Given this list of marker genes ATP6V1H, PPP4C, MYO5A, PPIC, NUP133, TMEM59, FRAT1, NBN, ITGAE, EFCAB11, AMDHD2, PFKL, KCNAB2, APPBP2, TMEM41B, XPO7, MAGED1 (NCBI Gene Id 9500), NPRL2 (NCBI Gene Id 10641), KRT1, IRF2, HSBP1, OARD1, TM6SF1, DYSF, PDCD4, NPTN, CASP8AP2, NXT2, BTN3A1, RUBCN (NCBI Gene Id 9711), TM2D1, MEAK7, TRPM2, ALOX5AP, SNRNP25, CTSH, LPCAT4, GIMAP6, LAPTM5, PTPN12, CDC7, TASOR, NDRG3, COL18A1, SLC9A1, PCYT2, CC2D1A, VIPAS39, ACTR1A, LAGE3, ATP5PD, INPP5B, RIPOR1, MICU1, PATZ1, ACADS, ENO3, GNB1, PEX14, OSTM1, NFKBIL1, CLIP1, YAF2, VOPP1, TDP2, UBE4A, MDC1, MKRN1, SH3BGRL3, NEK9, KIAA0319, PIGG, ITPR2, CHMP6, THEMIS2, STRADA, NTHL1, ST3GAL5, DHCR24, CAND1, ZNF682, E2F3, ERCC3, ECHDC2, CLUAP1, SOS1, MINPP1 (multiple inositol-polyphosphate phosphatase 1), PHYH, CDK19, KYAT1, HSD17B7, MED16, NFU1, MAP3K5, CSNK1G2, SLF2, PIGF, RMI1, AKAP7, CPT1A, ZYX, ATM, ANKZF1, PDE4DIP, XPNPEP1, PURA, ORC4, PHF20, SMC1A, SUMO2, MRFAP1L1, ITPK1 (inositol-tetrakisphosphate 1-kinase), MSRB2, EEIG1, SPOCK2, OSTF1, NAA40, WWP2, INPP5A, PARP4, WWC3, PCF11, LOXL2, C1orf159, CYB5R3, ADCK2, GNAI2, HTT, ABHD17A, SLC37A1, ZNF43, UBA3, HERC2, ILRUN, MRPL34, GTF2E1, DOK1 (NCBI Gene Id 1796), ACTL6A, BCL7C, LY96, YIPF1, PAQR4, ZNF266, CDIPT, LRRC20, IARS2, RCBTB2, NDUFA8, TRAF3IP1, CCDC69, ALDH3A2, NDUFS8, PPT1, CEP76, TMEM94, AMBP, MAPKAPK3, SLC33A1, FAM32A (family with sequence similarity 32 member A), FAIM, VAV1, INPP5E, AP3S1, MBP, NOTCH2, SHFL, ATAD2, MTMR1, SLC25A10, STAP1, KIF26B, OGFRL1, CZIB, USP39, KCTD2 (NCBI Gene Id 23510), PLK4, RAP1GDS1, PMVK, YLPM1, FANCG, F2RL1, LEPROTL1 (leptin receptor overlapping transcript like 1), ATP6V1A, DDC, RPL13P5, LAMTOR2, OMD, TPGS2, MAT2B, E2F1, AGL, EP300 (E1A binding protein p300), STX7, SV2A, HDAC6 (NCBI Gene Id 100820762), SQOR, THOC7, USP21, here is a description of the gene set: Expression profiling of Rag2-deficient Ets1++ and Rag2-deficient Ets1-- mature NK cells and WT bone marrow progenitors, WT T cells, and WT Pro B cells Human Gene Set: GSE37301_LYMPHOID_PRIMED_MPP_VS_CD4_TCELL_DN studied in species Homo sapiens from publication Ramirez K, Chandler KJ, Spaulding C, Zandi S, Sigvardsson M, Graves BJ, Kee BL (PMID 22608498) Genes down-regulated in lymphoid primed multipotent progenitors versus CD4 T cells.